Given this list of marker genes TMEM131L, IFNL1 (NCBI Gene Id 282618), MIR30B, PTPN22, MDK, LAX1, FGL2, TGFB1, PPARA, LGALS9, CD69, WNK1, NRARP, CTSG, ADORA2A, SOCS5, SOCS6, PLA2G2A, IL2, ILDR2, MIR222, XCL1, DTX1, MIR125A (NCBI Gene Id 406910), TNFRSF21, GNRH1, PDCD1LG2, LILRB1, PRDX2, MIRLET7E, TNFSF4, RUNX1, IL4I1, LILRB2, PTPN2, HLA-DRB1, PTPN11, SHH, PELI1, IL2RA, TNFAIP8L2, LGALS3, SDC4, LAPTM5, CCL28, LGALS1 (galectin 1), TNFRSF14, FOXP3, RAG2, ANXA1, HLA-G, CTLA4, BMP4, CLEC4G, DLG1, TWSG1, CBLB, IL10, VSIR, TIGIT, LAG3, NDFIP1, CBFB, ZBTB7B, HLA-E, ITCH, DLG5 (NCBI Gene Id 9231), CD274, ERBB2, CR1, CD300A, MIR181C, AKT1, KLF4, LRRC32, IRF1, SPN, CRTAM, PLA2G2F, LGALS9C, PAG1, IHH, TARM1, ARG2, SCRIB, CD80, TNFSF18, PLA2G2D, PTPN6 (protein tyrosine phosphatase non-receptor type 6), MIR27A, RC3H2, LILRB4 (NCBI Gene Id 11006), HMGB1, IFNA2, SFTPD, ARG1, PRNP, CD86, PDCD1, BTLA, ASCL2, RUNX3, IL20RB, CEBPB, CDKN2A, IFNB1, VSIG4, VTCN1, TBX21, UFL1 (UFM1 specific ligase 1), BCL6, MIR31, RC3H1, GLMN, SMAD7, MIA3, ZC3H12A, MAD1L1, STAT5A, GPNMB, ZC3H8, MIR21, MIRLET7G, CSK (NCBI Gene Id 1445), SLC4A2 (solute carrier family 4 member 2), LGALS9B (galectin 9B), IDO1, SCGB1A1, BTN2A2, PAWR, MIR221, CD74, CASP3, GLI3, DUSP3, CXCL12, SOCS1, JAK3, CCL25, PRKAR1A, IL4R, CD37, LOXL3, MIR141, TSPAN32, CCL21, FGL1, DAPL1, PLA2G5, DUSP22, HFE, ASS1, MARCHF7, ADTRP, FOXJ1, HAVCR2, HLX, MIR146A, RIPOR2, here is a description of the gene set: Any process that stops, prevents or reduces the frequency, rate or extent of leukocyte cell-cell adhesion. Human Gene Set: GOBP_NEGATIVE_REGULATION_OF_LEUKOCYTE_CELL_CELL_ADHESION species: Homo sapiens